Given this list of marker genes Gm15808, Npy (NCBI Gene Id 68398), Nxph1, Gm5148 (predicted gene 5148), Pcp4, Ciita (class II transactivator), Slc35f4, Fgf12, Gm15155, Btbd6, Smim17, Caly, Fgf3, Ccdc120, Iqsec3, 1700123O21Rik, Kcnc2, 4930509J09Rik, A230077H06Rik, Pou6f2, Panx2, Trank1, Has3, Gm23054, Lypd1, Cdh23, Htr4, Hmx2, Esrrb, Cacng3, Rph3a, Kcna4, Akain1, Lyrm1, Tmem30c, Gm17893, Tmem240, Rasgef1a, Cdh9, Chd5, Cacna1i, Grm5, Gria1, Pitpnm1, here is a description of the gene set: from publication Cao J, Spielmann M, Qiu X, Huang X, Ibrahim DM, Hill AJ, Zhang F, Mundlos S, Christiansen L, Steemers FJ, Trapnell C, Shendure J (PMID 30787437) Mouse Organogenesis Cell Atlas (MOCA) DE_gene_main_cluster.csv, fold.change>=1.5, qval<0.05, pval<0.05 species: Mus musculus Mouse Gene Set: DESCARTES_ORGANOGENESIS_INHIBITORY_NEURONS